The following is a description of a gene set: The process in which two or more actin filaments are connected together by proteins that act as crosslinks between the filaments. The crosslinked filaments may be on the same or differing axes. studied in species Homo sapiens Human Gene Set: GOBP_ACTIN_CROSSLINK_FORMATION, and this is the list of marker genes: MARCKS, EPS8, GAS2L3, BAIAP2L2, DIAPH3, AIF1, GAS2L2, BAIAP2L1, GAS2, BAIAP2, GAS2L1, FLNA, LCP1, DPYSL3